Given this list of marker genes EIF2AK4 (eukaryotic translation initiation factor 2 alpha kinase 4), PRKAR1A (protein kinase cAMP-dependent type I regulatory subunit alpha), NLRC4, HLA-DPA1, WAS, HMOX1, IRF2BP2, NPM1, HLA-DPB1, ZBTB16 (zinc finger and BTB domain containing 16), SLC35A1, SLC7A7, PDCD1, COPA, PRTN3, STAT3 (signal transducer and activator of transcription 3), CTCF, STAT5B, ENG, NABP1, CTLA4, ZNFX1, PTPN22, RARA, COL3A1, NUMA1, PML, SP110, BCOR, WIPF1, FIP1L1, TBL1XR1, here is a description of the gene set: Pulmonary hemorrhage Human Gene Set: HP_PULMONARY_HEMORRHAGE Pulmonary hemorrhage is a bleeding within the lungs. Older children and adults may spit blood or bloody sputum. Neonates, infants and young children usually do not spit up blood. Anemia, pulmonary infiltrates, increasingling bloody return on BAL and the presence of hemosiderin-laden macrophages in broncho-alveolar lavage (BAL) fluid or lung biopsy can diagnose lung bleeding. Alveolar macrophages contain phagocytosed red blood cells and stain positive for hemosiderin, a product of hemoglobin degradation, after about 48-72 hours following pulmonary hemorraghe. Previous or recurrent bleeding can thus be distinguished from fresh events. A differentiation into local or diffuse is of importance. Also differentiate if pulmonary hemorrhage is due to a primary lung disorder or a manifestation of a systemic disease. species: Homo sapiens